Given this list of marker genes PLOD3, BUD23, OTX2, GFI1, GPR35, MTAP (NCBI Gene Id 8008), NAGA, PYCR1, SOS2, GNRHR, KISS1R, NPR2, FARSB, NR5A1, DUSP6, CHD7, GTF2IRD2, SLC10A1, EIF4H, SERPINA1, TAC3, ASCC3, PROKR2 (prokineticin receptor 2), GORAB, PLEKHM1 (NCBI Gene Id 9842), GLI2, MGAT2, MDM4, BAZ1B, RECQL4 (RecQ like helicase 4), GSTM3 (NCBI Gene Id 2947), MRPS22, IER3IP1, DNAJC30, IFT56, TACR3, GNAS, CYP3A4, SGMS2, MLXIPL, SPIDR, LHX4, HBB, SLC35A2, IKBKG, HMOX1, RFC2, LZTR1 (leucine zipper like post translational regulator 1), SLC6A14, FBXO11, FBN1, CDC73 (cell division cycle 73), AIP, HECW2 (NCBI Gene Id 57520), SKI, TNFRSF11B, NAF1, ALG3, CAVIN1, NF1 (neurofibromin 1), HFE, IRX5, SPRY4, MRAS, PPIB, TONSL, PRLR, SH3PXD2B, GCM2, GNPTAB, XYLT2, SOS1, ZNF668, TAPT1, MTX2, RRAS2, MMP1, CEACAM3, CBFB, TRAF3IP1, PLOD2, ATP7A, POU1F1, ZFX, SLC2A2, PROP1, USP9X, CTCF, LIMK1 (LIM domain kinase 1), MAFB, SEMA4D, COX4I2, MMP2, FSHR (NCBI Gene Id 4959), TINF2, CLCA4, SEC24D, MIF, COL7A1, HNRNPK, PHLDB1, TMEM67, SNORD115-1, TRPS1, MIA3, LAMA5, ESR1, SEC23A, ADAMTSL2, ADCY10, PTPN11, FLRT3, POLE, PMM2, KRAS, PIK3CD (NCBI Gene Id 5293), POLR3A, FKBP14, IL6, CHST3, BNC1, CRIPT, EDNRA, DDOST, SLC17A5, STX3, SLC34A1, PIGU, SLC26A9, RNU4ATAC, SLC39A8, FOXA2, TRPV6, MAN2B1, SLC12A1, CEACAM6, KISS1 (NCBI Gene Id 3814), CTC1, SLC11A1, MMP14, UROD, SERPINH1, PSAP, SPRED2, PAPPA2, DNA2, HLA-DRB1, AARS1, PWRN1, NPAP1, VPS37D (VPS37D subunit of ESCRT-I), B4GALT7, SATB2, PRKAR1A, IFITM5, TNNC2, ERCC2, ATP6V0A2, STX1A, MTTP, DCHS1, CYP19A1, LRP5, POLR3H, COL5A2, RIT1, RPL11, GBA1, PROK2, FKBP10, POC1A, DPM2, NFKBIA, KCNN4, B3GALT6, COG1, TMEM270, P4HB, FBN2, ANTXR2, SMAD3, MPLKIP, SLC9A3, IGF1, IFIH1 (interferon induced with helicase C domain 1), IARS2 (NCBI Gene Id 55699), RNF125, NAA20 (NCBI Gene Id 51126), SMARCD2, DNAJC21, PSMC3IP, KL, CBL, BRAF, LIFR, STN1, PIGY, NUP107, CCND1, GTF2I, TBL2, BMP2, COL1A1, RIGI, SBDS, AFF3, GCLC, SNORD116-1, AEBP1, ADAMTS2, HESX1, UROS, TCF4, TARS1, GEMIN4, RSPRY1 (ring finger and SPRY domain containing 1), B3GAT3, SLC39A13, LACC1, TREM2 (NCBI Gene Id 54209), PRKACA, GNRH1, CYP27A1, HERC2, SLC7A7, HPGD, MBTPS2, SOX3 (NCBI Gene Id 8256), NHLH2, NSMF, ELANE, TERT, FGFR2, ATP8B1, MKRN3, DCTN4 (dynactin subunit 4), ANAPC1 (NCBI Gene Id 64682), RRAS, UNC80, COL5A1, PYGL, FKBP6, KNSTRN, FBLN5, FGF8, SCARB2, METTL27, SNRPN, ZNF699, NCF1, ZSWIM7, HS6ST1, FUT8, HRAS, SIM1, MAGEL2, CFTR, IL17RD, ERI1, PWAR1, AVP, LTBP4, GTF2E2, OCA2, NOTCH2, TCIRG1, ZMPSTE24, PDE11A, EED, CDKN1C, CLPB, FGFR1, FAT4, P3H1, TMEM38B, EFL1, GTF2H5, HSD17B4, KCNJ1, GPAA1, PIGT, BMP15, AGK, SMPD1, SMARCAL1, MSH4, MEN1, GNPAT, STAT1, CRTAP, CLIP2, CREB3L1, WDR11, GATA1, ELN, FGF17, TAF1, HNRNPH1, RASA2, IFT140, NDN, ANO5, NHERF1, RAF1, RNF113A, ERCC3, TGFB1, STAT3, IL1RN, GLIS3, PTH1R, GTF2IRD1, SLC37A4, CARS1, CDH23, LMNA, COPB2, ALDH18A1, NRAS, SRP19, MST1, TCF12, PLOD1, here is a description of the gene set: Human Gene Set: HP_OSTEOPENIA species: Homo sapiens Osteopenia Osteopenia is a term to define bone density that is not normal but also not as low as osteoporosis. By definition from the World Health Organization osteopenia is defined by bone densitometry as a T score -1 to -2.5.